The following is a description of a gene set: studied in species Homo sapiens Role of ABL in ROBO-SLIT signaling Human Gene Set: REACTOME_ROLE_OF_ABL_IN_ROBO_SLIT_SIGNALING, and this is the list of marker genes: ROBO1, CAP1, ABL2, ABL1, CLASP2, CLASP1, CAP2, SLIT2